The following is a description of a gene set: Any process that stops, prevents, or reduces the frequency, rate or extent of signal transduction mediated by the MAPKKK cascade. studied in species Homo sapiens Human Gene Set: GOBP_NEGATIVE_REGULATION_OF_MAPK_CASCADE, and this is the list of marker genes: NHERF1, DUSP16, AIDA, DUSP1, PRMT1, CSK, GPER1, MIR483, PIK3CB, STYXL2, MEN1, DUSP7, SERPINB3, MIR185, EPHA4, RGS14, ATF3, MYC, TAOK3, RNF149 (ring finger protein 149), CBLC, CHRNA10 (cholinergic receptor nicotinic alpha 10 subunit), DUSP3, DLG1, GPS2, F2RL1, ASH1L, DAG1, MIR221, UCHL1 (ubiquitin C-terminal hydrolase L1), SMAD4, PPP5C, PER1, IGF1R, PRKN, ACE2, SH3RF2 (SH3 domain containing ring finger 2), LAX1, PBK, DNAJA1, HIPK3, SIRT3, PRDM15, LEMD2, AGT, MIR26A1, DUSP29, SPRED2, MIR92A1, GSTP1, DEFB114, ITGB1BP1, NLRP6, NF1, MIR218-1, MARVELD3, VRK3, TNIP1, KLF4, TREM2, SH2B3, ITCH, MECOM, MIR200C, NLRP12, RASGRF1, SEMA6A, DUSP4, SPRED3, LILRB4, CD300A, PIN1, EFNA1, DUSP6, TLR4, PEBP1, PPIA, FOXO1, CHRNA9, APOE, DUSP26, IL1B, EMILIN1, RPS6KA6, DUSP8, FKTN, DSG3, EPHB2, TRIB3, PPARG, PDCD4, SPRY4, MIR503, NF2, DAB2IP, MIR205, CAV1, IRAK3, IGF1, PTPRC, PIK3R2, ZMYND11, PAQR3 (NCBI Gene Id 152559), CYLD, TRIB1, SBNO1 (strawberry notch homolog 1), RANBP9, DUSP13B, MIR133A1, MAPK8IP1, RGS2, MIR133B, FBLN1, TBC1D10C, FLCN (folliculin), DUSP5, ERRFI1, PTPN2 (NCBI Gene Id 5771, protein tyrosine phosphatase non-receptor type 2), PPEF2, ABCA7 (NCBI Gene Id 82843), ZNF675, IGBP1, GBP1, LYN, SPRY3, PTPN22, CDK5RAP3, PTPN6, EZR, CRYBA1, GBA1, XBP1, AMBP, NPPA, PINK1, WNK2, C3orf33, SPRY1 (sprouty RTK signaling antagonist 1), SPRED1, EIF3A, ADIPOQ, SH3GL2, PAFAH1B1, PTPN1, PTPRJ, DUSP2, SMPD1, PP2D1, PRKCD, DAB2, PSMD10, MIR21, ABL1, CAV3, SPRY2, MIR20A, QARS1, CNKSR3, SIRPA, C1QL4, DUSP10, CDK12, P2RX7, DUSP19, LMO3, PHB1, KLHL31, LIF, DACT1, DUSP9, NCOR1 (nuclear receptor corepressor 1), MIR138-1, FOXM1, BTN2A2, NDRG2, PTPRR, STK38, PSCA, HDAC3, MIR424, SYNJ2BP, TLR9